The following is a description of a gene set: Human Gene Set: HP_PARAGANGLIOMA species: Homo sapiens Paraganglioma A carotid body tumor (also called paraganglionoma or chemodectoma) is a tumor found in the upper neck at the branching of the carotid artery. They arise from the chemoreceptor organ (paraganglion) located in the adventitia of the carotid artery bifurcation., and this is the list of marker genes: MAX, ATRX, SDHA, DLST, KIF1B, SDHB, CCND1, DNMT3A, NF1, RET, SDHC, SLC25A11, FH, SDHAF2, MDH2, VHL, EPAS1 (endothelial PAS domain protein 1), TMEM127, SDHD